Given this list of marker genes ARL8B, GPR107, SAP30L, SIK3, NAPG, BTBD3, FAXDC2, FBXW11, DLG1, MRTFB, OCIAD1 (NCBI Gene Id 54940), CCDC25, NIPA1, IL6ST, TF, HERC4, MTMR4, PTK2, EPB41L3, ZNF565, ERBIN, PRRG1, MAPK10, GORASP1, PHLPP2, MAP4K4, AIDA, SLAIN1, RTN4, CCDC92, MAPK8IP3, GOLGA7, MOAP1, DYNC1I2, CLDND1, EFCAB14, TAFA5, SELENOI, NAPEPLD, ATG2B, ABHD6, TNS2, BLTP1, NCS1, PLEKHA1, HERC2, ZER1, CAMK2G, FAM219A, GPRC5B, PDP1 (NCBI Gene Id 5497), RNF13, GLTP, TSNAX, DNAJB14, PLEKHB1, SH3GLB2, TBC1D10B, SUN2, HIGD1A, FAM168B, ARHGAP21, ZNF710, ATP2B2, LANCL1, RAPGEF2, STAMBP, KLHL21, FBXO9, MARF1, PRXL2A, CERT1, KCNJ10, DDHD2, IPO5, IQSEC1, PREPL, NPTN, FRYL, here is a description of the gene set: studied in species Homo sapiens Human Gene Set: GCM_DLG1 Neighborhood of DLG1 discs, large homolog 1 (Drosophila) in the GCM expression compendium Neighborhood of DLG1